Given this list of marker genes Serpinb9c, Gm15222, Slc13a5, Zfp456, Parp12, Stfa3, Gm16035, Stfa1, Fuom, Lyz2, Mirt1, Ms4a3, Fcnb, Olfm4, Cstdc4, Chi3l1, Adcy10, Slpi, Mmp8, 5730409E04Rik, Gda, Stfa2l1, Camp, Prap1, Mmp9, S100a9, S100a8, Ltf, Ngp, Hp, Abca13 (ATP-binding cassette, sub-family A member 13), Lcn2, Pglyrp1, Cstdc5, Csta2, Elane (elastase, neutrophil expressed), Dnmt3c, Fgr, Xdh, Gpr68, here is a description of the gene set: Mouse Organogenesis Cell Atlas (MOCA) DE_gene_main_cluster.csv, fold.change>=1.5, qval<0.05, pval<0.05 Mouse Gene Set: DESCARTES_ORGANOGENESIS_NUETROPHILS from publication Cao J, Spielmann M, Qiu X, Huang X, Ibrahim DM, Hill AJ, Zhang F, Mundlos S, Christiansen L, Steemers FJ, Trapnell C, Shendure J (PMID 30787437) studied in species Mus musculus